Given this list of marker genes GLYAT, GLYATL1B, GLYATL2, GLYATL3, GLYATL1, here is a description of the gene set: Human Gene Set: GOMF_GLYCINE_N_ACYLTRANSFERASE_ACTIVITY Catalysis of the reaction: acyl-CoA + glycine = CoA + N-acylglycine. species: Homo sapiens